The following is a description of a gene set: Human Gene Set: GOBP_CD8_POSITIVE_ALPHA_BETA_T_CELL_PROLIFERATION The expansion of a CD8-positive, alpha-beta T cell population by cell division. studied in species Homo sapiens, and this is the list of marker genes: VSIR, SH3RF1, SLC4A2, XCL1, HLA-A, MAPK8IP1, IRF1, HLA-E